Given this list of marker genes NGFR, ARHGEF33, MCF2, BEX3, MAPK8, ARHGEF40, VAV1, NCSTN, ARHGEF5, PLEKHG2, MCF2L, APH1B, NGF, ARHGEF16, ARHGEF18, UBA52, YWHAE, SOS1, TRIO, PSENEN, RASGRF2 (NCBI Gene Id 89993), FGD3, AATF, OBSCN, NET1, NGEF, ARHGEF19, FGD4, PREX1, SOS2, RAC1, SQSTM1, UBC, TIAM2, ARHGEF38, ARHGEF2, TIAM1, VAV2, ITGB3BP, PLEKHG5 (pleckstrin homology and RhoGEF domain containing G5), GNA13, MAGED1, UBB, PSEN2, ARHGEF26, ARHGEF6, ARHGEF39 (Rho guanine nucleotide exchange factor 39), CASP2 (NCBI Gene Id 835), ARHGEF1, ARHGEF7, ARHGEF9, ARHGEF10L, VAV3, ARHGEF11, ARHGEF35, AKAP13, APH1A, ARHGEF12, FGD2, TRAF6, RPS27A, ARHGEF17, BAD (BCL2 associated agonist of cell death), ARHGEF37, ITSN1, ARHGEF15, PSEN1, ECT2, CASP3, ABR, ARHGEF3, KALRN, ARHGEF4, BCL2L11, ARHGEF10, FGD1 (NCBI Gene Id 2245), here is a description of the gene set: p75NTR is a key regulator of neuronal apoptosis, both during development and after injury. Apoptosis is triggered by binding of either mature neurotrophin or proneurotrophin (proNGF, proBDNF). ProNGF is at least 10 times more potent than mature NGF in inducing apoptosis. TRKA signalling protects neurons from apoptosis. The molecular mechanisms involved in p75NTR-apoptosis are not well understood. The death signalling requires activation of c-JUN N-terminal Kinase (JNK), as well as transcriptional events. JNK activation appears to involve the receptor interacting proteins TRAF6, NRAGE, and Rac. The transcription events are thought to be regulated by another p75-interacting protein, NRIF. Two other p75-interacting proteins, NADE and Necdin, have been implicated in apoptosis, but their role is less clear. part of: p75 NTR receptor-mediated signalling studied in species Homo sapiens Reactome Pathway: Cell death signalling via NRAGE, NRIF and NADE